Given this list of marker genes Igkj1, Igkj3 (NCBI Gene Id 16076), Igkv3-12-1, Rpl34-ps1, Grid2, 0610030E20Rik, Igkv4-92, Igkv14-130, Igkv10-95, Sftpb, Igkv4-80, 2610300M13Rik, Igkv12-38, Igkv1-122, Spmip9, Igkv17-127, Il23r, Igkv12-40, Igkv13-84, Igkv4-90, Krcc1, Vmn1r39, Igkv13-73-1, Rpl19-ps9, Ggcx, Igkv4-69, Foxi3, Igkv15-103, Igkv10-94, Igkv2-95-2, Igkv13-64, Gm5307, Rnf103, Vmn1r-ps24, Igkv9-123, Igkv5-43 (immunoglobulin kappa chain variable 5-43), Igkv2-105, Mrpl35, Igkv1-35, Hpgds, Igkv1-133, Igkv5-45, Igkv6-20, Igkv12-47, Igkv10-96, Igkv8-18, Gm19078, D530018E20Rik, Igkv15-101-1, Gm6157, Igkv12-46, Igkv8-22, Igkv14-126, Igkv7-33, Igkv13-85, Igkv4-59, Gm8574, Igkv8-21, E230016M11Rik, Igkv4-65, Igkv4-53, Igkv13-87, Kdm3a, Igkv8-19 (NCBI Gene Id 620440), Igkj4, Igkj2, Gm40377, Igkv2-137, Gadd45a, Igkv14-118-2, Igkv14-126-1, Gm6786, Rmnd5a, Smarcad1, Gm19131, Gm15490, Igkv4-57, Gm8862, Igkv3-12, Igkv3-6, Igkv4-71, Gm8479, Gm40414, Igkv13-62-1, Igkv9-128, Igkv1-117, Gm5310, Igkv8-28, Igkv4-62, Igkv12-89, Igkv4-91, Gm18716, Sh2d6, Igkv13-76, Atoh1, Vamp8, Igkv15-102, Igkv11-106, Gm24911, Nasp-ps1, Igkv9-129, Igkv14-111, Igkv2-109, Prdm5, Fabp1, 9130221F21Rik, Rpl18a-ps3, Igkv3-3, Igkv5-48, Gm4761, Gm17825, Mat2a, Gm8828, Gm20445, Gm8848, Igkv3-10, Elmod3, Ndnf, Vmn1r37, Gm5309, Gm31520, Gm29848, Tcf7l1, Capg, Igkv1-136, Particl, Gm8872, Igkv20-101-2, Igkv2-95-1, Vmn1r38, Gm19764, Gm9729, Il12rb2, Igkv12-41, Gm9728, Gm8853, Igkv4-78, Igkv4-70, Serbp1, Igkv13-80-1, Rpl18a-ps2, Reep1, Rn7s6 (NCBI Gene Id 19814), Igkv13-54-1, Igkv4-86, Gm18980, Igkv3-4, Igkv9-119, Igkv5-40-1, Gm5001, Igkv2-107, Gm5876, Gm18402, Rnf181, 1700040L08Rik, Igkv11-114, Igkv12-67, Igkv6-29, Igkv9-120, Tacstd2, Igkv6-15, Igkv12-98, Gm18913, Igkv8-27, Tmem150a, Eif2ak3, Gm38832, Cd8b1, Gm1070, Igkv13-55-1, Igkv4-54, Igkv5-37, Igkv4-73, 4930515G16Rik, Chmp3, Igkv6-17, Vmn1r33, Gm5308, Gm23485, Igkv8-26, Gm4374, Gm8566, Immt, 4930597O21Rik, Gm22425, Gm25436, Igkv1-88, Igkv4-51, Igkv1-99, Igkv8-31, Gm25833, Igkv4-68, Suclg1, 9330118I20Rik, Igkv6-32, Igkv19-93, Igkv13-61-1, Igkv4-56, Vmn1r35, Mad2l1, Igkv3-9, Igkv4-60, Gm26628, Igkv3-2, Ptcd3, Igkv5-39, Smyd1, Igkv2-113, Vamp5, Igkv4-57-1, Igkv4-83, Gm8836, Gm15534, Igkv13-56-1, Igkj5, Igkv1-108, Igkv18-36, Gm22212 (NCBI Gene Id 115490451), Igkv3-11, Gm25260, Igkv1-135, Igkv3-8, Igkv16-104, Kcmf1, Igkv1-115, Gm24533 (predicted gene, 24533), Snord94, Gm17147, Igkv13-57-1, Gm20177, Vmn1r32 (vomeronasal 1 receptor 32), Igkv6-13, Igkv15-97, Igkv3-5, Gm6794, Thnsl2, Gm8952, Igkv8-30, Cd8a, Tnip3, 4933431G14Rik, Igkv14-134-1, Igkv4-61, Or6g1-ps1, Gm38825, Gm9794, Igkv13-57-2, Tgoln1, Igkv3-1, Amd-ps5, Igkv15-101, Igkc, Igkv12-42, Igkv6-25, Igkv12-66, Gm44419, 4930544G11Rik, Igkv8-34, Igkv4-79, Igkv14-100, Gm6063, Igkv4-63, Igkv4-77, Polr1a, Igkv11-125, Gm44083, Igkv2-112, Gm30211, Igkv2-116, Jkampl, Gm3549, Igkv4-50, Gm25205, Igkv17-121, 1700065L07Rik, Igkv1-131, Vmn1r36, Igkv6-23, Igkv1-110, Retsat, Igkv13-74-1, Igkv4-81, Igkv17-134, Gm4873, Igkv4-75, Igkv4-55, Igkv12-44, Atoh8 (NCBI Gene Id 71093), Igkv13-71-1, Igkv1-132, Gm31747, Igkv6-14, Usp39, Qrfprl, Igkv8-16, Igkv3-7, Gm20144, Gm18540, Igkv13-78-1, Gm23346, Gm44768, Rprl1, St3gal5, Igkv4-74, Gm36816, Igkv14-118-1, Mir8112, Rpia, Igkv8-24 (immunoglobulin kappa chain variable 8-24), Igkv12-49, Gm4045, Igkv4-58, Gng12, Igkv2-93-1, Gm23625, Igkv11-118, Igkv13-82, Igkv9-124, Gm16838, Gm25910, Igkv4-72, Gm15401, Vmn1r34, Dnah6, Gm20560, Gm15644, Tmsb10, Gm18839, here is a description of the gene set: Mouse Gene Set: chr6C1 studied in species Mus musculus